Given this list of marker genes PDCD1LG2, RTN3, ILDR1, NUPR1, HYCC1, CAMK1D, IFNAR2, SFT2D1, LTB, WHAMM, PDE2A, GNL2, MTPAP, FNBP1, CSNK1G3, AATF, CDC37L1, PTPN23, TCF12, MIPOL1, TOM1, RYBP (RING1 and YY1 binding protein), ATXN1L (NCBI Gene Id 647512), SLC26A11, MAP3K8, CCRL2, CTPS1, FOXN2, WNK1, MYBPC2, CPEB4, POU2AF1, TRIM44 (tripartite motif containing 44), FCHSD2, CNR2, MIDEAS, GMFG, CBFB, CLINT1, WASHC4, CMTM7, HLA-B, HLA-G, SYTL3, RELL1, ARHGAP17, SFSWAP, SERP1, MARCHF3, TANK, CCNT1, NUS1, NEDD4L, CDYL2, GNAQ, CIITA, THRA, METTL2B, NT5C3A, NCOA4, EARS2, RLF, CCNL1, C15orf48, DTNB (NCBI Gene Id 1838), OPTN, EIF4E3, RNF2, NR1D2, IRS2, EXOC5, IGF2R, MZT1, IRF2BP2, POLR3D, CD40, PRKAR1A, SCO1, GIMAP6 (NCBI Gene Id 79765), CIPC, USP16, FAM120AOS, NINJ1, EIF2AK3, ZNF841, PDS5A, ST6GALNAC4, PTDSS1 (phosphatidylserine synthase 1), RBM48, KCTD18, ZNF18, QTRT2, FEM1C, PLGRKT, TBC1D25, FLCN, OSGIN2, CYTH1, PLPBP, MAPK7, EPC1, GSTT2, ALG11, XPC, GAPVD1, MYSM1, STAP1, FAM168B, GPR183, CHST7 (NCBI Gene Id 56548), DTX1, LITAF, CXCL10, CD164, FAM167A, RPRD2, ARHGAP15, RANBP2, NFE2L2, CRISP3, MAP4K3, TMEM88, STK40, TUG1, WIPF1, ZSCAN26, TBC1D12, FYN, RBM34, APOBEC2, GPR137B, GTPBP4, CACFD1, BRAF, ILF3, BANK1, ERO1A, TMEM222, MYO1E, PRKAA1, RFTN1 (raftlin, lipid raft linker 1), FAM185A, GLCCI1, SGK1, SH2D5, MAT2A, STK17B, M6PR, NFATC1, AZIN1, PANK4 (pantothenate kinase 4 (inactive)), LYSMD3, CD74, CLUH, STAMBPL1, MAU2 (MAU2 sister chromatid cohesion factor), BTG1, DNASE1L3, CASP6, CHD3, MAFK, AZI2, PEA15, LARP4B (La ribonucleoprotein 4B), HLA-DOA, ERRFI1, TK2, DDIT3, BIRC3, VPS16, ZFAND2A, PURA, TIMM9, BFAR, TP53INP1, PSD3, GPAT3, UCKL1, CD82, ZNF622, EIF5, CAPN5, RIPK2, SNX4, EDARADD, RBBP8, KDSR (NCBI Gene Id 2531), BAG5, VPREB3, GARRE1, RNF216, CDC42BPG, VEZF1, PPP1R3C, EZR, NT5DC3, MINDY2, FGL2, IFRD1, ATP6V0D1, here is a description of the gene set: species: Homo sapiens Genes up-regulated in CD4 T cells: untreated versus IL1B, IL6 and IL-23. from publication Ghoreschi K, Laurence A, Yang XP, Tato CM, McGeachy MJ, Konkel JE, Ramos HL, Wei L, Davidson TS, Bouladoux N, Grainger JR, Chen Q, Kanno Y, Watford WT, Sun HW, Eberl G, Shevach EM, Belkaid Y, Cua DJ, Chen W, O'Shea JJ (PMID 20962846) CD4+ T cells that selectively produce interleukin (IL)-17, are critical for host defense and autoimmunity1-4. Crucial for T helper17 (Th17) cells in vivo5,6, IL-23 has been thought to be incapable of driving initial differentiation. Rather, IL-6 and transforming growth factor (TGF)-β1 have been argued to be the factors responsible for initiating specification7-10. Herein, we show that Th17 differentiation occurs in the absence of TGF-β signaling. Neither IL-6 nor IL-23 alone efficiently generated Th17 cells; however, these cytokines in combination with IL-1β effectively induced IL-17 production in naïve precursors, independently of TGF-β. Epigenetic modification of the Il17a/Il17f and Rorc promoters proceeded without TGF-β1, allowing the generation of cells that co-expressed Rorγt and T-bet. T-bet+Rorγt+ Th17 cells are generated in vivo during experimental allergic encephalomyelitis (EAE), and adoptively transferred Th17 cells generated with IL-23 in the absence of TGF-β1 were more pathogenic in this experimental disease. These data suggest a new model for Th17 differentiation. Consistent with genetic data linking the IL23R with autoimmunity, our findings re-emphasize the role of IL-23 and therefore have important implications for the development of new therapies. Human Gene Set: GSE23505_UNTREATED_VS_4DAY_IL6_IL1_IL23_TREATED_CD4_TCELL_UP